The following is a description of a gene set: from publication Delpuech O, Griffiths B, East P, Essafi A, Lam EW, Burgering B, Downward J, Schulze A (PMID 17452451) Genes down-regulated in DL23 cells (colon cancer) upon expression of an activated form of FOXO3. studied in species Homo sapiens Human Gene Set: DELPUECH_FOXO3_TARGETS_DN Forkhead transcription factors of the O class (FOXOs) are important targets of the phosphatidylinositol 3-kinase (PI3-kinase)/Akt pathway. FOXOs have been implicated in the regulation of cell cycle progression, oxidative stress resistance, and apoptosis. Using DNA microarrays, we analyzed the transcriptional response to FOXO3a activation by gene expression analysis in DLD-1 colon cancer cells stably expressing a FOXO3a.A3-ER fusion protein. We found that activation of FOXO3a resulted in repression of a number of previously identified Myc target genes. Furthermore, FOXO3a activation induced expression of several members of the Mad/Mxd family of transcriptional repressors, most notably Mxi1. The induction of Mxi1 by FOXO3a was specific to the Mxi1-SR alpha isoform and was mediated by three highly conserved FOXO binding sites within the first intron of the gene. Activation of FOXO3a in response to inhibition of Akt also resulted in activation of Mxi1-SR alpha expression. Silencing of Mxi1 by small interfering RNA (siRNA) reduced FOXO3a-mediated repression of a number of Myc target genes. We also observed that FOXO3a activation induced a switch in promoter occupancy from Myc to Mxi1 on the E-box containing promoter regions of two Myc target genes, APEX and FOXM1. siRNA-mediated transient silencing of Mxi1 or all Mad/Mxd proteins reduced exit from S phase in response to FOXO3a activation, and stable silencing of Mxi1 or Mad1 reduced the growth inhibitory effect of FOXO3a. We conclude that induction of Mad/Mxd proteins contributes to the inhibition of proliferation in response to FOXO3a activation. Our results provide evidence of direct regulation of Mxi1 by FOXO3a and imply an additional mechanism through which the PI3-kinase/Akt/FOXO pathway can modulate Myc function., and this is the list of marker genes: LARS1, UBE2C, AARS1, SNHG32, NUSAP1, IMPDH2, EPB41L4A-AS1, DTYMK, APEX1, MB, SLC7A1 (NCBI Gene Id 6541), TIAL1, GADD45A, SLC1A4, MTHFD2, PITX2, EFNB2 (NCBI Gene Id 1948), PFN2, MKI67, EXOSC8, NEK2, PYCR1, XPOT, SHMT2, KIF22, CDC42EP3, SMC4, CEBPG, PCK2, IARS1, FOXM1, AURKA, AREG (amphiregulin), PRC1, ZWINT, VEGFA, NUPR1, HAX1, H1-0, CENPF